Given this list of marker genes Pkp3, Numb, Cdh26, Jup, Vcl, Cdh1, Ptprt, Ajuba, Cdh2, Pkp2, Ctnnb1, Cdh24, here is a description of the gene set: Mouse Gene Set: GOMF_ALPHA_CATENIN_BINDING studied in species Mus musculus Binding to catenin complex alpha subunit.